The following is a description of a gene set: Human Gene Set: GOCC_POSTSYNAPTIC_EARLY_ENDOSOME studied in species Homo sapiens An early endosome of the postsynapse. It acts as the major sorting station on the endocytic pathway, targeting neurotransmitter receptors for degregation or recycling., and this is the list of marker genes: SNX27, EEA1, VPS26B, SNX6, GRIPAP1